The following is a description of a gene set: A trimeric protein complex that phosphorylates inhibitory-kappaB (I-kappaB) proteins. The complex is composed of two kinase subunits (alpha and beta) and a regulatory gamma subunit (also called NEMO). In a resting state, NF-kappaB dimers are bound to inhibitory IKB proteins, sequestering NF-kappaB in the cytoplasm. Phosphorylation of I-kappaB targets I-kappaB for ubiquitination and proteasomal degradation, thus releasing the NF-kappaB dimers, which can translocate to the nucleus to bind DNA and regulate transcription. species: Homo sapiens Human Gene Set: GOCC_IKAPPAB_KINASE_COMPLEX, and this is the list of marker genes: CHUK, PYCARD, IFIT5, PYDC1, TRIM40, IKBKG, ERC1, IKBKB